The following is a description of a gene set: Any process that activates or increases the rate of neuroblast proliferation. studied in species Mus musculus Mouse Gene Set: GOBP_POSITIVE_REGULATION_OF_NEUROBLAST_PROLIFERATION, and this is the list of marker genes: Fgf2, Ctf2, Cip2a, Sox10, Nr2e1, Id4, Ctnnb1, Cx3cl1, Prl2c2, Itgb1, Cx3cr1, Aspm, Vegfa, Wdr62, Mapk8, Dct, Pax6, Gli3 (NCBI Gene Id 14634), Hif1a, Smo, Dmrta2, Drd2, Otp, Zfp335, Kdm1a, Bex1, Smarcd3, Foxg1, Fzd3, Vegfc, Notch1, Sox2 (SRY (sex determining region Y)-box 2), Cdon, Disc1, Shh